Given this list of marker genes DDIT4, NAP1L1, CEMIP, EIF4G3, SEMA3C, PODXL (NCBI Gene Id 5420), PHKB, EXT1, MYO10, USP32P2, UTRN, AP3B1, STX12, PIBF1, COL13A1, DDX10, VEGFC, STK39, SLIT2, SEMA5A, CXCL12, PPP2R3A, RASA1 (NCBI Gene Id 5921), SATB2, PAFAH1B1, LAS1L, MARF1, PTPRM, CDH18 (cadherin 18), SAMD4A, SLC20A2, DOCK1, HMGA2, NAV3, SIPA1L1, IGF1R, COL6A1, POLA1, TBC1D30, ANGPT1, MEIS2, DYNC1LI2, UBL3, XYLT1, IGFBP5 (NCBI Gene Id 3488), PRIM2, FTO, TPST1, PTPRK, CDK14 (cyclin dependent kinase 14), G6PD, EHBP1, C2CD2, CRADD, CDH2, FNBP1 (NCBI Gene Id 23048), PEX14, ZNF804A, GBE1, ERC1, WWOX, RBMS1, MICAL2 (microtubule associated monooxygenase, calponin and LIM domain containing 2), RFTN1, here is a description of the gene set: DNA damage caused by UV radiation initiates cellular recovery mechanisms, which involve activation of DNA damage response pathways, cell cycle arrest and apoptosis. To assess cellular transcriptional responses to UVC-induced DNA damage we compared time course responses of human skin fibroblasts to low and high doses of UVC radiation known to induce a transient cellular replicative arrest or apoptosis, respectively. UVC radiation elicited >3-fold changes in 460 out of 12,000 transcripts and 89% of these represented downregulated transcripts. Only 5% of the regulated genes were common to both low and high doses of radiation. Cells inflicted with a low dose of UVC exhibited transcription profiles demonstrating transient regulation followed by recovery, whereas the responses were persistent after the high dose. A detailed clustering analysis and functional classification of the targets implied regulation of biologically divergent responses and suggested involvement of transcriptional and translational machinery, inflammatory, anti-proliferative and anti-angiogenic responses. The data support the notion that UVC radiation induces prominent, dose-dependent downregulation of transcription. However, the data strongly suggest that transcriptional repression is also target gene selective. Furthermore, the results demonstrate that dose-dependent induction of cell cycle arrest and apoptosis by UVC radiation are transcriptionally highly distinct responses. studied in species Homo sapiens Selected genes down-regulated in WS1 (fibroblast) in response to irradiation with low dose UV-C. Human Gene Set: GENTILE_UV_LOW_DOSE_DN from publication Gentile M, Latonen L, Laiho M (PMID 12907719)